Given this list of marker genes POT1, RUVBL2, MACROH2A1, NEK7, TCP1 (NCBI Gene Id 6950), FEN1, SKA1, TFPT, SLX1A, SHCBP1L, SMC5, HSP90AA1 (heat shock protein 90 alpha family class A member 1), TNKS, CCT6A, NEK2, INO80B (NCBI Gene Id 83444), NBN, AURKB, SIRT6, DKC1, INO80, TERF1, YY1, PARN, NAF1, ACD, RAD21, ACTR8, SLF1, DDX11, INO80D, HNRNPD, PTGES3 (NCBI Gene Id 10728), NABP2, MAP2K7 (mitogen-activated protein kinase kinase 7), NCAPH, MAD2L1BP, TERF2IP, CCT8 (chaperonin containing TCP1 subunit 8), CCT7, BUB1, ATRX, NSMCE2, CCT2, ACTL6A, CTNNB1, TINF2, TPR, MAPK1, NCAPD3, HNRNPA2B1, NUMA1, TERF2, ATM, INO80C, SMC4, PRAP1, ATR, RTEL1, ACTR5, CCT4, PKIB, MAD1L1, SLX4, PML, DHX36, MAPK15, NCAPH2, MAP3K4, MCRS1, PNKP, KLF4, TNKS2, SLX1B, NVL, CCT5, MRE11, TAL1, PPP1R10, NCAPD2, MAPKAPK5, SFPQ, KAT5, RUVBL1, HNRNPA1, NCAPG2, FBXO4, LIG4, MAPK3, PRKCQ (NCBI Gene Id 5588), SKA3, GNL3, INO80E, UCHL5, WRAP53, ERCC1, SLF2, RAD50, NCAPG (NCBI Gene Id 64151), CDK1, CCT3, NFRKB, CDK2, SMC2, MYC (NCBI Gene Id 731404), here is a description of the gene set: Any process that activates or increases the frequency, rate or extent of chromosome organization. species: Homo sapiens Human Gene Set: GOBP_POSITIVE_REGULATION_OF_CHROMOSOME_ORGANIZATION